The following is a description of a gene set: studied in species Homo sapiens Muscle abnormality related to mitochondrial dysfunction Human Gene Set: HP_MUSCLE_ABNORMALITY_RELATED_TO_MITOCHONDRIAL_DYSFUNCTION, and this is the list of marker genes: ETHE1, AARS2, POLG2, COA8, NDUFS2, MT-TE, TIMMDC1, MT-CYB, DNA2, TRMT10C, FARS2, MT-ND6, TYMP, RRM1, MT-TL1, YARS2, NDUFB3, MT-TL2, MSTO1 (misato mitochondrial distribution and morphology regulator 1), NDUFB10, MT-ND4, COX6B1, COA3, TRMT5, SCO2, NDUFAF3, LIG3, NDUFB11 (NCBI Gene Id 54539), MT-CO3, MT-TS2, NDUFA1, MT-TC, MT-TW, ISCU, CAV3, RNASEH1, MT-TN, TRMU, FBXL4, NDUFAF8, AGK, SLC25A10, MT-CO2, NUBPL, NDUFS3, MT-TV, NDUFV2, TK2, NDUFA4, NDUFB9, MGME1, MT-ND3, NDUFA6, MT-TT, RRM2B, MRPL44, NDUFA11, MT-CO1, SLC25A42, FDX2, SLC25A4, GTPBP3, MT-TF, MT-ND5, SURF1, DGUOK, MT-TQ, NDUFAF5, BRAT1, TOP3A, MT-ND2, TACO1 (translational activator of cytochrome c oxidase I), MPV17, NDUFAF2, MT-ATP6, ATP5F1A, PNPT1, COX6A2, TMEM126B, NDUFAF4, COX10, NDUFS6, OPA1, POLG, MT-ND1, NDUFS7, MT-TK, NDUFS4, LRPPRC, PNPLA8, NDUFAF1, NDUFV1, NDUFS1, TFAM, MIEF2, FOXRED1, SUCLG1, PUS1, NDUFS8, TWNK